The following is a description of a gene set: Any process that activates or increases the frequency, rate or extent of actin filament-based movement. Mouse Gene Set: GOBP_POSITIVE_REGULATION_OF_ACTIN_FILAMENT_BASED_MOVEMENT studied in species Mus musculus, and this is the list of marker genes: Zeb2, Acta2, Atp2a1, Cacna1h, Ptger3, Strit1